Given this list of marker genes SLC4A7, SIKE1, ITCH, HERC4, PSMA5, DPP8, DIAPH3 (NCBI Gene Id 81624), H2AC25, NEDD4, STEAP3, DENND5B (NCBI Gene Id 160518), LY6E, ZC3HAV1L, GPSM2, GNAI1, KNL1, PAG1, ZNF367, GNL2 (NCBI Gene Id 29889), AGPS, TPR, SLC30A5, HEATR1, LYAR, VKORC1L1, NOP58, ITGB1BP1, RTCA, CKLF, C5orf34 (NCBI Gene Id 375444), GLRX, PSRC1, GON7 (NCBI Gene Id 84520), WDHD1, CCSAP, MKKS, GUF1, CCPG1 (cell cycle progression 1), FANCD2, EIF5B, EMSY-DT, MRPS16, KPNA4, AGFG1, RFC1, EIF2S1, SGO2, BRCA1, SSX2IP, IMPDH1, DYNC2H1, UCHL5, GLRX2, DCUN1D4, CMC2, CD58, GFM2, AMELX, SNHG4, EGLN1, CBS, PTPN12, PSMD8, PTPN14, CACYBP, TLK1, FERMT2, MANEA, HAUS6, CCNE1, RRM1, DCAF13, TUSC3, STMN1, KIRREL1, SSR3, MTHFD2, DNAJC2, ZC3H7A, APC, CCT6A, GMPS, ABCD3 (ATP binding cassette subfamily D member 3), GPT2, MAD2L2, SFXN1, PPP1R14B, DBF4, SUPT16H, PCNA, MRTO4, SLC7A11, CDCA7, TMED5, MCM4, H2AZ1, LAPTM4B, MIS18A, EIF5A, ANLN, MRPL42, CPSF2, PHLDA2, ASNS, GPD2, UCK2, DNAJC9, HAT1, PHF14, MASTL, SGCB, ZNF146, CPSF3, TOPBP1, LARP1B, DNAL1, RESF1, SLMAP, SS18, ABCE1, STC2, TYMS, SOCS4, PAQR3, NBN, DNM1L, CTDSPL2, CRNDE, KIF20B, NLN, BMS1, TBC1D7, RPL26L1, STAM2, TPM4, C5orf22, SMG1P2, RPRD1A, GTPBP4, CCT8, GFM1, CENPW, MCM8, CENPN, ATXN3, NPM1, ELOC, TSN, CKAP2, TOX2, PRKDC, NICOL1, ZNF780B, P4HA2, ARL6, MAPK1, SRGAP2, IDE, YTHDF3, ITGB3BP, NAA15, ENO1, TIMM23, UTP15, NCAPG, SASS6, TMEM45A, FBXO22, CUL4B, SPDL1, TSEN15, ASXL2, PPP4R3B, CIP2A, MYBL1, BBIP1, TFRC, RFWD3, PLAUR, NDC1, ATP1B3, NEMF, MOB1A, DPY19L1, FEN1, MCM7, PRPF40A, BCHE, RASAL2, GART, SOAT1, SRSF10, ENSG00000248161, EIF2S3, GEMIN2, BUB1B, H2BC7, EPHX4, LEO1, POLH, MED6, ROR1, SHCBP1, VPS35, DDR2, LZIC, TRIP11, C4orf46, PRELID1, ATIC, NRAS, WDR75, KIAA0586 (KIAA0586), EIF4G2, IL7R, OSBPL3, RACGAP1, ATP6V1C1, RSRC1, PRTFDC1, MTFP1, RAB5IF, MTHFD1L, NAMPT, FAM72C, TMPO, DTYMK, NUSAP1, CBX5, LRIF1, CDK1 (cyclin dependent kinase 1), MAP4K5, PPP2R3C, NCBP2, TTF2, PNP, RAP1GDS1, FRYL, KPNA2, GRPEL2, PSMA3, TFDP2, IL6ST, CENPQ, GINS2, ATL3, EPRS1, MAN1A2, KBTBD2, CDKAL1, NADK2, UBE2C, SLC25A32, CBFB, IKBIP, ZWINT, CIT, RAD51C, IGF2BP3, ZC3H15, ADAM9 (ADAM metallopeptidase domain 9), SGCE, TMEM161B, GALC, HCCS, VPS50, MTREX, AP1AR, WDR4, SMC3, DHFR, FH, RAP2A, SNHG26, HMGB3, ATAD2, PLPP2, PVR, LMNB2, IFT56, NABP1, CHEK1, ENO2, COA7 (NCBI Gene Id 94485), MFN1, HOXB7, DNAJC10, MCMBP, MKI67, CCNA2, LNPEP, REEP3, NQO1, SEL1L, COLGALT1, GLRX3P2, ZBTB8OS, STIL, HLTF, GARS1, MAD2L1, CCNB1, KIF1B, PRKAA1, EXOC5, NETO2, TOMM22, SPIRE1, PBK, TRUB1, LIN9, HPS3, NNT, CEBPG, FUS, P4HA1, DNTTIP2, PMS1, RAD51AP1, TLCD4, CENPU, SRPK2, FAM89A, RAN (NCBI Gene Id 87046), CCDC34, SAR1A, FAM200B, KISS1R (KISS1 receptor), TNFRSF10B, GAS2L3, SIPA1L1, SCD, PSMG1, MICU1, DERL1, DONSON, HSPA4, CKS2, ARL5B, MBNL1, BUB3, ZNF644, UBE2V2, GSPT1, WDR41, MKLN1, LRR1, CSNK1G3, AMIGO2, NME1, BNIP3L, ABCF2, CTPS1, PSAT1, MTIF2, SNX13, NIFK, ENC1, ITGB1, FIGNL1, PARPBP, DBT, SMG1P5, PMAIP1, FXR1, TFAM, DDX3X, IL1RAP, SLC39A14, MTFR2, IQGAP3, ERCC8, RABGGTB, NEMP1, CFI, MSH6, HSPA4L, DCUN1D1, STAM, PSMC3IP, CYCS, CEBPZ, CHRNA5, ACOT7, CCNE2, AURKA, OSTM1, P3H1, LRPPRC, TTL, KIF18A, TNFRSF12A, HSPA14, CLIC4, GLRX3, OGFOD1, GEN1, GINS1, CCDC14, WDR76, ERLIN1, ELOVL6, GDI2, PFDN4, PACC1, CYP51A1, PRR11 (proline rich 11), AIMP1, TIMM17A, UBE2M, GPNMB, FAM216A, RPE, CSE1L, SLC39A9, PHTF1, ERO1A, NXPH4 (NCBI Gene Id 11247), UBE2W, SEC61A2, GMFB (glia maturation factor beta), GTPBP10, CDKN2B, PI4K2A, EIF2S2, CANX, RARS1, RALGPS2, ANXA1, WDR3 (NCBI Gene Id 10885), PAICS, SMC4, MICAL2, SLC16A1, MRPL47, CENPF, RFC2, TPGS2, YIPF5, EDRF1, C5orf24, UBA6, PPAT, NUDT5, GPX8, HYLS1, CYTOR, H2BC12, PHTF2, PRC1, EVI5, DLGAP5, TMEM167A, YWHAZ, BRIX1, INTS7 (integrator complex subunit 7), SUV39H2, SINHCAF, RPAP3, KLHL7, SNAPC1, KIF2C, PNPT1, HACD1, BCCIP, SRSF6, UPP1, NDUFV3, SSBP1, SUB1, AK4, ARMC9, WDR12, H2BC6, EIF4EBP1, ARSB, FBXO5, POLD2 (DNA polymerase delta 2, accessory subunit), NUP155, KIF5B (kinesin family member 5B), C1orf43, ORC6, RBAK, C16orf87, RHOBTB3, LDB1, AP2S1, CCDC88A, FANCI, PDCD5, ECT2, GTSE1, TUBG1, SAR1B, RBBP4, SUGT1, RCC1, PSMA2, COA1, GNAI3, RNASEH2A (NCBI Gene Id 10535), WAPL, DNMT1, MIPOL1, TIPRL, CALU, MCM6, FAM168B, HSPD1, ASAH2, GGCT, ZWILCH, TIPIN, GALE, ME2, C15orf48 (chromosome 15 open reading frame 48), CCDC77, IFI16, RBBP8, DDX39A, UBE2S, DHX9 (NCBI Gene Id 3450), AVPI1, SESN2, HSPA13, CA5BP1, COPS8, MPHOSPH10, GTF2H2, LEPROTL1, ZEB1, YME1L1, NUP50, TANK, ORC5, SPCS3, YKT6, JPT1, USP47, SCAMP1, AVEN (NCBI Gene Id 57099), PAPOLA, MRPS9, FAF1, LINC00662, LONP1, U2SURP, TWF1, BTG3, CHAC2, CTSA, UGGT2, CTSC, PSPH, SMC2, SETD9, MRPL13, AGPAT5, RIF1, NHLRC2, NOP16, CSNK1A1, CDC123 (cell division cycle 123), MCM2, SERPINH1, GPR180, PSMD14, CLDN1, HSPA9, DSN1 (DSN1 component of MIS12 kinetochore complex), ODF2L, PAM16, E2F5, NASP, GIN1, SRGAP2B, TARS1, ACP1, BOLA2, AFF4, ATR, BRWD1, RFC4, TMEM30A, RAI14, SLF1, GFPT1, KIF2A, PLOD3, FKBP14, TMEM97, GOLGA7, DKK3, THAP9-AS1, GPC1, TNFSF9, SRD5A1, RAD18, HAUS1, HELLS, MATR3, MRPL37, KNTC1, USP16, HMGB2, GOT1, LACTB2, MRPS12, GSR (NCBI Gene Id 2936), KIF14, MTFR1, LMNB1, CHCHD3, SMC6, TTK, PHGDH, XRCC4, AK6, CBX3 (chromobox 3), SEH1L, ACTR2, ADSL, PXDN, H2BC9, NMD3, RBL1, NPM3, AGGF1, SNCA, H2BC12L, SLC2A1, EXOSC9, CDC6, USP1, CFL2, NUDT21, CARS1, SNRPD1, SSR1, DTL, OSMR, NOLC1, SEPTIN10, CKS1B, KCTD5, here is a description of the gene set: from publication Rodrigues RF, Roque L, Krug T, Leite V (PMID 17406368) Genes up-regulated in poorly differentiated thyroid carcinoma (PDTC) compared to normal thyroid tissue. Information on gene alterations associated to poorly differentiated (PDTC) and anaplastic thyroid carcinomas (ATC) is scarce. Using human cancer cell lines as a tool for gene discovery, we performed a cytogenetic and oligo-array analysis in five new cell lines derived from two PDTC and three ATC. In PDTC we evidenced, as important, the involvement of the MAPK/ERK kinase pathway, and downregulation of a group of suppressor genes that include E-cadherin. In ATC, downregulation of a specific group of oncosuppressor genes was also observed. Our ATC cell lines presented chromosomal markers of gene amplification, and we were able to identify for the first time the nature of the involved amplicon target genes. We found that the main molecular differences between the two cell line types were related to signal transduction pathways, cell adhesion and motility process. TaqMan experiments performed for five amplicon target genes and for two genes, which allowed a clear distinction between ATC and PDTC: CDH13 and PLAU corroborated array results, not only in the cell lines, but also in an additional set of primary 14 PDTC and three ATC. We suggest that our findings may represent new tools for the development of more effective therapies to the hitherto untreatable ATC. Human Gene Set: RODRIGUES_THYROID_CARCINOMA_POORLY_DIFFERENTIATED_UP studied in species Homo sapiens